The following is a description of a gene set: Mouse Gene Set: GOBP_FC_EPSILON_RECEPTOR_SIGNALING_PATHWAY The series of molecular signals initiated by the binding of the Fc portion of immunoglobulin E (IgE) to an Fc-epsilon receptor on the surface of a target cell, and ending with the regulation of a downstream cellular process, e.g. transcription. The Fc portion of an immunoglobulin is its C-terminal constant region. species: Mus musculus, and this is the list of marker genes: Fcer1g, Fcer1a, Nr4a3, Fer, Fcgr4, Fcer2a